Given this list of marker genes FOXP1, ENHO (NCBI Gene Id 375704), EP300, ITGB8, EIF1, GGNBP2, SAMD8, PFKFB3, RBM24, BCL7A, ASIC3, LMO4, DET1, CHST11, PHOX2A, JUNB, PDIK1L, CPEB3, BMP2, JADE2, KLF16, BRSK1, FEV, POLR2A, PRDM10, ATOSB, DNMT3A, ZFY, PHF6, CFAP161, CALM3, ARHGAP6, PRKCH, FTHL17, TFE3, CKMT1B, ZNF436, CDX1, CHCHD7, RAB5IF, CIMIP2A, PPP2R5E, GLRA1, FLT1, MEMO1, UBE2O, KLHL18, MAPK10, FOXN3, TMEM256, HSD3B7, EIF4G1, STAG2, HOXB6, MAP1A, BCL6B, YWHAE, LAMA1, CTDSP1, NKIRAS2, RTF1, GADD45G, BARHL1, RHOG, MAML1, ROM1, PCIF1 (phosphorylated CTD interacting factor 1), EFNB3, AHNAK, HNRNPL, MARCHF5, ZNF436-AS1 (NCBI Gene Id 148898), JOSD2, PLTP, RNF112, IKZF5, CHD2 (chromodomain helicase DNA binding protein 2), FAF1, BCL3, GRM7, PLAG1, MIB1, EPHB1, STAT3, ASPHD1, PRKCG, XRN2, KIF9, EVA1C, SEC24C, SH3BP5L, MORF4L2, IRS1, SPAG7, CIMAP1A, POGLUT1, RAB34, PLEKHM1, PABPC3, PATZ1, CREB3L1, USP2, KCNJ11, PRDM8, SCN5A, SLC6A14, PPP2R5D, RASGRP2, MARCKSL1, SMTN, NECTIN1, TPBG, MAGED2, POFUT1 (protein O-fucosyltransferase 1), KLF14, ATP5MC1 (NCBI Gene Id 516), WNT10A, CDAN1, TNNI2, MIP, SLC12A5, TAOK2, APH1A, UBE2R2, CD248 (CD248 molecule), CDC73, RNF40, ASCL1, TSSK1B, CRY1, ZNF341, PPARD, LDHB, TBCC, MIR17HG, RBBP7 (RB binding protein 7, chromatin remodeling factor), HDAC3, CNFN, ADGRB2, MPL, ITPKA, PIM1 (NCBI Gene Id 82453), PODN, ARHGAP45, CADM2, H1-0, REV3L, TRERF1, STN1 (NCBI Gene Id 79991), TMOD4, NLK, PURA, KDELR1, CASKIN2, KCNIP2, ASB7, CNTN2, THAP11, AMER1, TCEAL9, HHEX, ZBTB9, ST8SIA4, EED, LINS1, GRIN2B (glutamate ionotropic receptor NMDA type subunit 2B), ADAMTS7, DNAJC7, CACNA1G, NFATC4 (NCBI Gene Id 4776), CDK6, JUP, ADAMTSL4, CNTFR, HOXC4, EMX2, XPR1, NPR2, AGER, TMEM8B, NR2E1, KCMF1, LSM14A, AGO3, NOL4, BDNF, OTX2, FZD2 (NCBI Gene Id 2535), SP3, PBX2, NR1D1, GHDC, PLAGL2, ZDHHC14, FXR2, ADAM11 (ADAM metallopeptidase domain 11), HOXB8, RTN4, ZBTB4, MANEAL, MTF2, PABPC1, DNAJB5, IRF2BPL, ZP1, ADAMTS3, AGBL5, LHX2, SPA17, NLGN2, PRKAG1, PRRT3, RAB11B, CDK16, RBP5, GSK3B, VWCE, TSEN54, MAPRE3, ACADSB, FRMD4A, EML3, LAMP2, RELL2, FBRS, CLSTN3, TMEM255A, GRIN2A, NEO1 (NCBI Gene Id 4756), FUT8, SLC4A2, ALDOC, SCUBE3, ZFHX3, TMEM125, CDH3, FOXP4, TOB1, SIAE, LIN28A, ANKRD17, ZFX, FUNDC1, BMP7 (bone morphogenetic protein 7), DUSP14, RUNX1, TTPAL (NCBI Gene Id 79183), TAC3, ZNF703, here is a description of the gene set: Genes having at least one occurrence of the motif ASMCTTGGGSRGGG in the regions spanning 4 kb centered on their transcription starting sites. This matches the SP3 transcription factor binding site V$SP3_Q3 (v7.4 TRANSFAC). species: Homo sapiens Human Gene Set: SP3_Q3